The following is a description of a gene set: Mouse Gene Set: GOBP_KIDNEY_MORPHOGENESIS species: Mus musculus Morphogenesis of a kidney. A kidney is an organ that filters the blood and excretes the end products of body metabolism in the form of urine., and this is the list of marker genes: Tacstd2, Fmn1, Agtr2, Grem1, Irx1, Smad4, Wt1, Pspn, Irx2 (NCBI Gene Id 16372), Greb1l, Tgfb1, Vangl2, Agtr1a, Pgf, Hs3st3b1, Fgf2, Dspp, Wnt11, Pax8, Hs2st1, Erbb4, Adamts16 (NCBI Gene Id 328284), Pbx1, Wnt2b, Npnt, Lzts2, Mir216b, Dlg1, Lgr4, Gata3, Hes5 (hes family bHLH transcription factor 5), Eya1, Asxl1, Hoxa11, Lama5, Wnt6, Nphp3, Gdnf, Foxj1, Ptch1, Zmpste24, Ctnnb1, Ctns, Mir217, Wnt4, Hs3st3a1, Pkd1, Tshz3, Hnf1b, Lhx1, Gcnt4, Ahr, Kif26b, Ilk, Six1, Cited1, Gcnt1, Sox4, Shh, Ppp3ca, Lif, Hoxd11, Timeless, Pax2, Wnt7b, Fras1, Wnt9b, Wnt1, Bmp4, Sox8, Mir216a, Stat1, Pkd2, Bcl2, Commd5, Foxd1, Six2, Cd44, Cited2, Wnk4, Vegfa, Smo, Hes1, Klhl3, Fgf1, Bmp2, Maged1, Tmem59l, Six4, Calb1, Gcnt3, Hey1, Fgf10, Fgf8 (NCBI Gene Id 14179), Lrrk2, Dchs1, Gzf1, Wwtr1, Prkx, Sall1, Agt, Gli3, Tcf21, Agtr1b, Fat4, Hoxb7, Nog, Gpc3, Sox9, Bmp7, Irx3, Osr1, Myc, Ctnnbip1